The following is a description of a gene set: studied in species Rattus norvegicus Inflammatory cytokines and their receptors moduated in brain tumors in response to treatment with cyclic RGD peptide prior to the oncocytic virus therapy. from publication Kurozumi K, Hardcastle J, Thakur R, Yang M, Christoforidis G, Fulci G, Hochberg FH, Weissleder R, Carson W, Chiocca EA, Kaur B (PMID 18042934) BACKGROUND: The tumor microenvironment is being increasingly recognized as an important determinant of tumor progression as well as of therapeutic response. We investigated oncolytic virus (OV) therapy-induced changes in tumor blood vessels and the impact of modulating tumor vasculature on the efficacy of oncolytic virus therapy. METHODS: Rat glioma cells (D74/HveC) were implanted intracranially in immune-competent rats. Seven days later, the rats (groups of 3-7 rats) were treated with oncolytic virus (hrR3), and, 3 days later, brains were harvested for evaluation. Some rats were treated with angiostatic cRGD peptide 4 days before oncolytic virus treatment. Some rats were treated with cyclophosphamide (CPA), an immunosuppressant, 2 days before oncolytic virus treatment. Changes in tumor vascular perfusion were evaluated by magnetic resonance imaging of live rats and by fluorescence microscopy of tumor sections from rats perfused with Texas red-conjugated lectin immediately before euthanasia. Leukocyte infiltration in tumors was evaluated by anti-CD45 immunohistochemistry, and the presence of oncolytic virus in tumors was evaluated by viral titration. Changes in cytokine gene expression in tumors were measured by quantitative real-time polymerase chain reaction-based microarrays. Survival was analyzed by the Kaplan-Meier method. All statistical tests were two-sided. RESULTS: Oncolytic virus treatment of experimental rat gliomas increased tumor vascular permeability, host leukocyte infiltration into tumors, and intratumoral expression of inflammatory cytokine genes, including interferon gamma (IFN-gamma). The increase in vascular permeability was suppressed in rats pretreated with cyclophosphamide. Compared with rats treated with hrR3 alone, rats pretreated with a single dose of cRGD peptide before hrR3 treatment had reduced tumor vascular permeability, leukocyte infiltration, and IFN-gamma protein levels (mean IFN-gamma level for hrR3 versus hrR3 + cRGD = 203 versus 65.6 microg/mg, difference = 137 microg/mg, 95% confidence interval = 72.7 to 202.9 microg/mg, P =.006); increased viral titers in tumor tissue; and longer median survival (21 days versus 17 days, P<.001). CONCLUSIONS: A single dose of angiostatic cRGD peptide treatment before oncolytic virus treatment enhanced the antitumor efficacy of oncolytic virus. Human Gene Set: KUROZUMI_RESPONSE_TO_ONCOCYTIC_VIRUS_AND_CYCLIC_RGD, and this is the list of marker genes: IL10RA, IL10, IL2RB, LTA, CCR8, CCR9, CCR2, CXCR1, CCL22, CXCL11, IFNG, CD40LG, CCL11, BCL6, CXCR2, CCR4, CCR5, CCR1, CXCL9, IL36RN, IL13